The following is a description of a gene set: species: Homo sapiens Human Gene Set: REACTOME_DEFECTS_IN_VITAMIN_AND_COFACTOR_METABOLISM Defects in vitamin and cofactor metabolism, and this is the list of marker genes: BTD (NCBI Gene Id 92108), MTR, LMBRD1, MCCC1, CBLIF (cobalamin binding intrinsic factor), MMAB, MMUT, PCCB, MMADHC, PCCA, MMAA, ABCD4, MCCC2, AMN, CUBN, MMACHC, TCN2, PC, ACACA, CD320, MTRR, HLCS